The following is a description of a gene set: studied in species Homo sapiens Human Gene Set: GOBP_MALE_GENITALIA_DEVELOPMENT The process whose specific outcome is the progression of the male genitalia over time, from its formation to the mature structure., and this is the list of marker genes: AR, CTNNB1, LHCGR, HSD17B3, SRD5A2, WNT9B, SYCP2, HOXD13, HOXA13, DHCR24, PDGFRA, ASB1, LGR4, SRD5A1, FGF8, SHH, TBX3, GREB1L, BMP5, BMP6, KLHL10, WT1, FGF10